The following is a description of a gene set: studied in species Mus musculus The chemical reactions and pathways involving a ribonucleoside monophosphate, a compound consisting of a nucleobase linked to a ribose sugar esterified with phosphate on the sugar. Mouse Gene Set: GOBP_RIBONUCLEOSIDE_MONOPHOSPHATE_METABOLIC_PROCESS, and this is the list of marker genes: Urah, Pals1, Nt5c3, Nudt2, Ak2, Uckl1 (uridine-cytidine kinase 1-like 1), Uprt, Ampd2, Pnp, Ak1, Dpys, Nt5c, Ak4, Adss2, Nt5c1b, Ppat, Impdh1, Ampd1, Cda, Dhodh, Hprt1, Adk, Guk1, Dck, Nt5e, Uox, Upb1, Upp1, Uck2, Aprt, Ak3, Paics, Impdh2, Gmps, Cad, Adss1, Prps2, Xdh, Pfas, Slc29a1, Dpyd, Gda, Gmpr, Nt5c2, Nt5c1a, Ampd3, Adsl, Urad, Gmpr2, Ada (adenosine deaminase), Umps, Prps1, Entpd1, Gart, Upp2, Uck1, Atic, Pals2, Rfk